Given this list of marker genes Wnt7b, Akr1b1, Umod, Pkd1, Calb1, Aqp2, Shh, Dact2, Tfap2b, Pax8, Notch1, Dlg5, Pax2, Spp1, Ptch1, Wnt9b, here is a description of the gene set: The process whose specific outcome is the progression of a collecting duct over time, from its formation to the mature structure. The collecting duct responds to vasopressin and aldosterone to regulate water, electrolyte and acid-base balance. It is the final common path through which urine flows before entering the ureter and then emptying into the bladder. Mouse Gene Set: GOBP_COLLECTING_DUCT_DEVELOPMENT species: Mus musculus